The following is a description of a gene set: from publication Nikolsky Y, Sviridov E, Yao J, Dosymbekov D, Ustyansky V, Kaznacheev V, Dezso Z, Mulvey L, Macconaill LE, Winckler W, Serebryiskaya T, Nikolskaya T, Polyak K (PMID 19010930) Human Gene Set: NIKOLSKY_BREAST_CANCER_15Q26_AMPLICON Genes within amplicon 15q26 identified in a copy number alterations study of 191 breast tumor samples. A single cancer cell contains large numbers of genetic alterations that in combination create the malignant phenotype. However, whether amplified and mutated genes form functional and physical interaction networks that could explain the selection for cells with combined alterations is unknown. To investigate this issue, we characterized copy number alterations in 191 breast tumors using dense single nucleotide polymorphism arrays and identified genes with copy number gain organized into 30 amplicons. Amplicons were distributed unequally throughout the genome. Each amplicon had distinct enrichment pattern in pathways, networks, and molecular functions, but genes within individual amplicons did not form coherent functional units. Genes in amplicons included all major tumorigenic pathways and were highly enriched in breast cancer-causative genes. In contrast, genes with somatic mutations in breast cancer were distributed randomly over the genome, did not represent a functionally cohesive gene set, and were relatively less enriched in breast cancer marker genes. Mutated and gained genes did not show statistically significant overlap but were highly synergistic in populating key tumorigenic pathways including transforming growth factor beta, WNT, fibroblast growth factor, and PIP3 signaling. In general, mutated genes were more frequently upstream of gained genes in transcription regulation signaling than vice versa, suggesting that mutated genes are mainly regulators, whereas gained genes are mostly regulated. ESR1 was the major transcription factor regulating amplified but not mutated genes. Our results support the hypothesis that multiple genetic events, including copy number gains and somatic mutations, are necessary for establishing the malignant cell phenotype. species: Homo sapiens, and this is the list of marker genes: CHSY1, LRRK1, SNRPA1, ADAMTS17, SYNM (synemin), CERS3, LRRC28, OR4F15, TTC23, ALDH1A3, TARS3, TM2D3, FAM169BP, LINS1, OR4F6, PCSK6, MEF2A, LYSMD4, SELENOS, IGF1R, ARRDC4, ASB7